Given this list of marker genes NPM1, OAS3, ABCE1, PDE3A, OAS1, HSPA1A, here is a description of the gene set: Any process that modulates the rate, frequency, or extent of ribonuclease activity, catalysis of the hydrolysis of phosphodiester bonds in chains of RNA. studied in species Homo sapiens Human Gene Set: GOBP_REGULATION_OF_RIBONUCLEASE_ACTIVITY